Given this list of marker genes SMG6, DHX36, XRN1, NAF1, TEP1, PINX1, GAR1, NOP10, EXOSC10, SNRPD3, TERT, PARN, DCP2, HNRNPC, SNRPB, SMG5, TENT4B, NHP2, WRAP53, HNRNPU (heterogeneous nuclear ribonucleoprotein U), DKC1, SMG7, here is a description of the gene set: studied in species Homo sapiens Binding to the telomerase RNA template. Human Gene Set: GOMF_TELOMERASE_RNA_BINDING